Given this list of marker genes PTAR1, IRF6, CAMTA1, CCDC87, SS18L1, NDUFS4, ARHGEF35, OSTM1 (osteoclastogenesis associated transmembrane protein 1), MTF2, AAK1, HTR1A, LPL, NAV1, CYP4B1, PMS1, TENT4B, STEAP2, EGR3, PANK3, EYA3, DACH1, ZIK1, MAN1A1, SH3TC2, CNR1 (cannabinoid receptor 1), ARB2A, PDE4D (NCBI Gene Id 654081), APOL4, PIK3C2B, CFLAR, KDM7A, HAUS6, GMFB, CDK19, MOSMO, TC2N, PCSK5, TM4SF18, MAGEB1, PDS5A, BASP1, ATRNL1, PCGF5, GNB4, MAP10, HSD3B2, ECRG4, MAS1, ARMS2, CIAO2A, HOGA1 (4-hydroxy-2-oxoglutarate aldolase 1), PABIR3, SLC6A12, here is a description of the gene set: from publication Chen Y, Wang X (PMID 31504780) Genes predicted to be targets of miRBase v22 microRNA hsa-miR-6888-5p in miRDB v6.0 with MirTarget v4 prediction scores > 80 (high confidence targets). Human Gene Set: MIR6888_5P species: Homo sapiens